The following is a description of a gene set: Human Gene Set: CAR_HPX Neighborhood of HPX Neighborhood of HPX hemopexin in the CAR expression compendium studied in species Homo sapiens, and this is the list of marker genes: C6, ANG, CFHR2, SERPINC1, CPS1, ITIH3, ORM1, APOF, HPX, MBL2, C8A, F9, AGT (angiotensinogen), FGL1, F2, HGFAC, UGT2B11, AKR1D1 (aldo-keto reductase family 1 member D1), DPYS, CDO1, APCS, CYP2C8, ARG1, TDO2, HRG, DHODH, GC, CYP2E1 (cytochrome P450 family 2 subfamily E member 1), FMO3, LPA, LECT2, AMBP, ITIH1 (NCBI Gene Id 3697), SERPINF2, FGG, SDS, SLC27A2, CYP3A7, SAA4, PON3, CYP2C9, C4BPA, IGFBP1, FGA, APOB, ADH6, C4BPB, F12, AADAC, TFR2, HP, SLC22A1, CPB2, HSD17B6, AQP9 (NCBI Gene Id 366), HPD, PAH, CFHR4, SERPIND1, APOC1, RBP4, APOA1, ASGR2, RIDA, C8B, FGB, ALDOB, SULT2A1, PLG, C9, CFH, G6PC1, AFM